Given this list of marker genes DGAT2L6, AWAT2, PNPLA3, DGAT1, DGAT2, PNPLA2, MGLL, here is a description of the gene set: Human Gene Set: REACTOME_ACYL_CHAIN_REMODELING_OF_DAG_AND_TAG Acyl chain remodeling of DAG and TAG species: Homo sapiens